Given this list of marker genes Cul3, Trappc12, Exoc6, Ykt6, Sar1a, Naglu, Ap1ar, Exoc6b, Map4k2, Tmed9, Chp1, Clasp2, Preb, Exoc7, Trappc4, 5730455P16Rik, Cep19, Tmed10, Klhl12, Nlgn1, Trappc6b, Trappc11, Arfgap2 (ADP-ribosylation factor GTPase activating protein 2), Exoc1, Trappc6a, Trappc13, Sar1b, Exoc4, Sec16a, Pclo, Exoc5, Clasp1, Psen1, Mapk15, Trip11, Pef1, Trappc2l, Exoc8, Stard3nl, Fam91a1, Exoc2, Dipk2a, Trappc3 (NCBI Gene Id 76909), Tmed10-ps, Pdcd6, Gbf1, Trappc9, Tbc1d23, Stard3, Wipi1, Arfgap3, Wdr11, Trappc10, Trappc2, Exoc3, Trappc5, Trappc1, Scrib, Ahi1, here is a description of the gene set: species: Mus musculus The process in which vesicles are directed to specific destination membranes. Targeting involves coordinated interactions among cytoskeletal elements (microtubules or actin filaments), motor proteins, molecules at the vesicle membrane and target membrane surfaces, and vesicle cargo. Mouse Gene Set: GOBP_VESICLE_TARGETING